The following is a description of a gene set: Human Gene Set: HP_INAPPROPRIATE_ANTIDIURETIC_HORMONE_SECRETION A state of increased circulating antidiuretic hormone despite hyponatremia and hypo-osmolality with normal or increased plasma volume. studied in species Homo sapiens Inappropriate antidiuretic hormone secretion, and this is the list of marker genes: LHX4, POU1F1, PPOX, HESX1, MOGS (mannosyl-oligosaccharide glucosidase), SP110, PROP1, LHX3